Given this list of marker genes EGR2, DBT, PHLDA1, ZBTB21, FAM13A, MGME1, BCOR, ZDHHC7, ARID4A, PRPSAP2, CREB3L4, ZBTB4, GNAQ, WDR73, ANAPC7, ATP6V0A1, RBM41, AKR1A1, HELZ, MRFAP1L1, ZFP3, CD180, STUB1, DSN1, ARHGAP12, TMEM175, INO80E, BTBD8, NFATC3, DNAJC9, PIP4K2B, FKBP15, PAGR1, GRK3, XPO7, APPL2, RXRA, PHF21A, EPB41, KLHL36, C2CD5, FOS, COMMD3, PRAM1, UBE4A, ING2, DRAM2, MBD4, TMEM17, AGO4, PLA2G15, TRIM32, IL16, FUT8, BMI1, MOSPD2, MOB3A, YEATS4, CWH43, TRMT12, PDS5A, DDX17, RNF7, EFCAB14, GALT, TLR5, MIOS, SNAP23, HK1, PYCARD, TGFBR2 (NCBI Gene Id 7048), CCSAP, TEF, KDM3A, ARL11, ZNF518B, UBR5, SELP, TMEM243, SFR1, IFFO1, CELF2, CLCN5, AVPI1, NAA40, ITSN1, ID2, DNAAF10, INPP4A, MANBA, STX10, GADD45G, TNFRSF11A, CBX3 (chromobox 3), UBAC1, RAB3D, EEPD1, PLAU, VPS8, PHF6, CBX1, MEF2C, TRIM8, TMEM121B, PAQR7, GPR146, TPST2, DOK3, DNMT1, RNF125, MKRN2, ZNF395, STAMBP, FAM78A, EIF3C, SPRY2, TRDMT1, NACC2, DUS4L, DOK2, TIGD2, STARD13, NUP155, GAS2L3, BAIAP2, UFSP2, AGAP3, MRPL55, REV3L, SPOPL, PDSS2, SLC22A15 (NCBI Gene Id 55356), LRRC58, METTL21A, ESCO1, UVSSA, ABL1, ARHGAP18, TPRG1L, PCMTD2, RAB42, GGPS1, XPO6, VPS26B, MTIF3, CEP85, ZRANB1, STK16, TUBGCP3, GABPB1-AS1, TBC1D14, MBOAT7, TWF2, ZNF589, IRS2, ABI2, TBL1XR1, MIDEAS, DAG1, AGPAT5, PITPNA-AS1, ARHGAP9, NFKBID, ZBTB1, PPIG, MTSS1, ALKBH5, TBC1D8B, HPS4, FGD3, RASA3, GIT2, CASP2, DAB2, KIFAP3, NMRAL1, DUSP10, PTDSS1, IRF2BP2, TMEM177, TCF12, ZC3H14, PRKAR1A, ZMYM3, ABCC5, CLN8, TXNDC12, SLC29A3, GLCCI1, RNMT, SH2D3C, TP53BP1, ATP10D, MAF, LHFPL2 (LHFPL tetraspan subfamily member 2), ELP5, here is a description of the gene set: To study effects of IFNalpha treatment on monocyte-derived macrophages which may influence susceptibility or resistance to HIV. from publication Greenwell-Wild T, Vázquez N, Jin W, Rangel Z, Munson PJ, Wahl SM (PMID 19556424) Human Gene Set: GSE16755_CTRL_VS_IFNA_TREATED_MAC_UP Genes up-regulated in comparison of control macrophages versus macrophages treated with interferon alpha. species: Homo sapiens